Given this list of marker genes Clec7a, Ang2, App, Elane, Clec4n, Ang6, Camp, Npy, Cd209b, Mpo, Tac1, Ptx3, Vip, Ncf1, Ang4, Ang, Ang5, Crk, Plcg2, here is a description of the gene set: Any process that results in a change in state or activity of a cell or an organism (in terms of movement, secretion, enzyme production, gene expression, etc.) as a result of a stimulus from a yeast species. Mouse Gene Set: GOBP_RESPONSE_TO_YEAST studied in species Mus musculus